Given this list of marker genes Bcl2l1, Abhd17c, Ubb, Rps27a, Lypla1, Calm1, Fnta, Hras, Zdhhc9, here is a description of the gene set: part of: RAF/MAP kinase cascade Reactome Pathway: RAS processing This event has been computationally inferred from an event that has been demonstrated in another species.<p>The inference is based on the homology mapping from PANTHER. Briefly, reactions for which all involved PhysicalEntities (in input, output and catalyst) have a mapped orthologue/paralogue (for complexes at least 75% of components must have a mapping) are inferred to the other species. species: Mus musculus electronically inferred by orthology from the curated human pathway